Given this list of marker genes COL6A1, CCND2, CDX1, MUC1 (NCBI Gene Id 4582), GAS6, FUT6, DPP4, COL6A2, CEACAM6, L1CAM, MVP, S100A9, CRISP3, CDKN1A, CILK1, CTTN, MMP1, IL11 (interleukin 11), AIM2, BCL6, SOD2, MMP13, here is a description of the gene set: from publication Murata-Kamiya N, Kurashima Y, Teishikata Y, Yamahashi Y, Saito Y, Higashi H, Aburatani H, Akiyama T, Peek RM Jr, Azuma T, Hatakeyama M (PMID 17237808) Selected genes up-regulated in WT-A10 cells (gastric epithelium) expressing the H. pilori virulence gene CagA. Human Gene Set: MURATA_VIRULENCE_OF_H_PILORI species: Homo sapiens Infection with Helicobacter pylori cagA-positive strains is associated with gastric adenocarcinoma. Intestinal metaplasia is a precancerous lesion of the stomach characterized by transdifferentiation of the gastric mucosa to an intestinal phenotype. The H. pylori cagA gene product, CagA, is delivered into gastric epithelial cells, where it undergoes tyrosine phosphorylation by Src family kinases. Tyrosine-phosphorylated CagA specifically binds to and activates SHP-2 phosphatase, thereby inducing cell-morphological transformation. We report here that CagA physically interacts with E-cadherin independently of CagA tyrosine phosphorylation. The CagA/E-cadherin interaction impairs the complex formation between E-cadherin and beta-catenin, causing cytoplasmic and nuclear accumulation of beta-catenin. CagA-deregulated beta-catenin then transactivates beta-catenin-dependent genes such as cdx1, which encodes intestinal specific CDX1 transcription factor. In addition to beta-catenin signal, CagA also transactivates p21(WAF1/Cip1), again, in a phosphorylation-independent manner. Consequently, CagA induces aberrant expression of an intestinal-differentiation marker, goblet-cell mucin MUC2, in gastric epithelial cells that have been arrested in G1 by p21(WAF1/Cip1). These results indicate that perturbation of the E-cadherin/beta-catenin complex by H. pylori CagA plays an important role in the development of intestinal metaplasia, a premalignant transdifferentiation of gastric epithelial cells from which intestinal-type gastric adenocarcinoma arises.